Given this list of marker genes BAP1, NR4A3 (NCBI Gene Id 8013), GSTP1, FLT3, CEACAM1, FBXO4, ITPKB, LIPA, UNCX, here is a description of the gene set: The multiplication or reproduction of common myeloid progenitor cells, resulting in the expansion of a cell population. A common myeloid progenitor cell is a progenitor cell committed to the myeloid lineage. studied in species Homo sapiens Human Gene Set: GOBP_COMMON_MYELOID_PROGENITOR_CELL_PROLIFERATION